Given this list of marker genes DPEP1, FOLH1B, MMP14, DPP3, CPXM1, ANPEP, ADAM17, FOLH1, MEP1A, NUDT16, AGBL2, RNPEPL1, CPA1, ACE2, ENPEP, NPEPPS, MMP16, CPZ, CPA2, CPB1, LNPEP, AGBL5, NAALAD2, ERAP2, NPEPPSP1, CPXM2, NPEPL1, CPA6, MME, AGBL1, METAP2, CPA5, VASH1, AGBL3, ACE, CPM, CPB2, CNDP1, VASH2 (NCBI Gene Id 79805), RNPEP, CNDP2, ADAM10, LTA4H, ERAP1, CPO, XPNPEP1, TRHDE, MMP17, AGBL4, AEBP1, CPQ, XPNPEP2, MMP15, ERMP1, CPA3 (NCBI Gene Id 1359, carboxypeptidase A3), DPEP2, CPA4 (carboxypeptidase A4), XPNPEP3, PREP, LAP3, MATCAP1, ZMPSTE24, CPN1, AGTPBP1, METAP1D, CPD (NCBI Gene Id 1362), CPE, METAP1, PRCP, AOPEP, PEPD, LVRN, here is a description of the gene set: Human Gene Set: GOMF_METALLOEXOPEPTIDASE_ACTIVITY Catalysis of the hydrolysis of a peptide bond not more than three residues from the N- or C-terminus of a polypeptide chain by a mechanism in which water acts as a nucleophile, one or two metal ions hold the water molecule in place, and charged amino acid side chains are ligands for the metal ions. studied in species Homo sapiens